The following is a description of a gene set: from publication Abbas AR, Baldwin D, Ma Y, Ouyang W, Gurney A, Martin F, Fong S, van Lookeren Campagne M, Godowski P, Williams PM, Chan AC, Clark HF (PMID 15789058) Genes up-regulated in comparison of memory IgM B cells versus blood plasma cells. Human Gene Set: GSE22886_IGM_MEMORY_BCELL_VS_BLOOD_PLASMA_CELL_UP studied in species Homo sapiens Immune cell-specific expression is one indication of the importance of a gene's role in the immune response. In order to identify such patterns, we set out to broadly profile gene expression in a variety of immune cells., and this is the list of marker genes: BTNL8, ATP6V0E2, DCK, BTG1, CDC42SE1, USP29, MAGEA12, BRD3, TEAD1, FMO5, ZNF345, NEIL3, C2CD3, PSTPIP2, SERPINE2, YPEL1, LYST, LINC00474 (NCBI Gene Id 58483), CA1, CLDN7, RFX5, CBFA2T2, ZNF202, CYP1A2, IRF8, DYNC2H1, VAV3, BRWD1, COLEC11, TNFSF12, ZNF211 (zinc finger protein 211), GSAP, CNTN2, HGSNAT, TRAF5, SLC4A4, UST, TNK2, LMOD1, GOLGA6A, RECK (NCBI Gene Id 8434), FRY, RPL32, CLEC4E, INPP5D, AHNAK2, RNF44, RPL11, ZNF532, CD82 (NCBI Gene Id 8052), PGGHG, MAB21L2, CXCR4, UBQLN3, HLA-DOB, RUFY2, FCMR, RPL27, GARRE1, ALK, MX2, FLNB (NCBI Gene Id 8413), CLCA1 (NCBI Gene Id 1179), GCA, PLEC, IFNA7, GGA2, CR2, ZNF286A, CSF1, TCF7, RPS20, PAMR1, SFTPB, PAX5, PKIA, TCFL5, SCARA3, SACS, METTL16, RPS12, CRYBG1, SLC46A3, OCA2, KYAT1, ADAMTSL3, CBX7, RPS23, RASGRF1, ZNF337, ING1, CDC42EP1, PRRC2B, WT1, KMO, SYNGR3, ZFP36L1, DTX4, HAO1, NXPE4, HLA-DMB, ATAD2B, TMEM8B, ZNF329 (zinc finger protein 329), FIG4, CD74, HAPSTR1, LAPTM5, MKRN3, HHEX, RPL30 (NCBI Gene Id 6156, ribosomal protein L30), EEIG1, NOTCH2, PRRG1, USB1, FBLN1, GNA14 (G protein subunit alpha 14), RPL39, HLA-DPB1, OBI1, DDX17, STAG3, PER2, ART1, ANKH, ANOS1, POLD4, PLA1A, SPP1, INTS9, CNR2, LRRN2, DGKA, LY86, CYP3A7, ZNF573, KLF7, RPL13A, APP, UTRN, HSPBAP1, KIR2DL2, ALDH1A3, JADE2, TSPAN1, PFDN5, LEPR, RGS7, KCTD7, RBFOX2, PWAR5, SPN, ZBTB18, TFAP2A, RADX, ENDOD1, ENAH (ENAH actin regulator), MFSD13A, FRK, TMEM151B, PKIG, CD2, BANK1, MAPRE2, PPBPP2, COL1A1, RETREG1, ABCA12, STAP1, SORD, PLSCR2, ERC2, OR7A17, ZCWPW1, STRADA, NFATC1, NCOA1, SOBP, KAT6A, SYNPO, FAM111A, CCDC144A, SYT11, CEP85, THRA, LINC00667, SLCO1A2, WWP2 (NCBI Gene Id 116013, WW domain containing E3 ubiquitin protein ligase 2), PIK3CD, SP110, ZNF23, SLC4A7, KIF13A, RPL26, MMRN2, CLDN8, RPL17, PTGS1